Given this list of marker genes Lmf1, Cables1, Gimap9, Dcc, Esr1, H2-D1, C1qtnf3, Cxadr, Cyp2c55, Acot2, Wscd2 (NCBI Gene Id 320916), Cxcl15, Anks3, Nptxr, Zfp746, ENSMUSG00000133272, Ahrr, Krtap1-5, Slit3, Enpp2, Parm1, Itgb5, 4930453N24Rik, Lyz2, Fbxo2, Slc4a10, Klf2, Col2a1, Endod1, Nat3, Plekha7, Cdh17, Lcp1, Agmo, Loxl4, Lama5, Camk4, Scarb2, Cpeb2, Col19a1, Ppm1l, Sema3d, Sod3, Spef2, Lyz1, Slamf9, Eppk1, Iqcg, Racgap1, Lratd2, H2-DMa, Hira, Macc1, Pcolce2, Sdsl, Phlda2, Myo1d, Cd59a, Csdc2 (NCBI Gene Id 223704), Ly6f, Rex2, Cep72, Galnt13, Sema3c, Vav3, Wnt7b, Pycr1, Rasgrp3, Erlec1, Tacc1, Fkbp10, Pgbd5, Gvin1, Ddx18 (NCBI Gene Id 66942), Kcnmb1, Hoxd13, H2-K1, Pde4b, Ly6g2, Fam107a, Mlip, Mcpt8, B4galnt4, Tent5a, Tgfb2, AU021092, Aplp1, Asrgl1, Gtsf1, Tspan13, Ntn4, Sh3bgr, Efna5, Lrrn4cl, Atf3, Colec10, Aldh1a7, Upk3b (NCBI Gene Id 231783), Aars2, Slc2a3, Slc22a18, Itih5, here is a description of the gene set: from publication Gaussmann A, Wenger T, Eberle I, Bursen A, Bracharz S, Herr I, Dingermann T, Marschalek R (PMID 17130830) Down-regulated genes from the set A (Fig. 5a): specific to cells expressing MLL-AF4 fusion protein alone. The reciprocal chromosomal translocation t(4;11) is correlated with infant, childhood, adult and therapy-related high-risk acute leukemia. Here, we investigated the biological effects of MLL.AF4, AF4.MLL or the combination of both reciprocal fusion proteins in a conditional in vitro cell culture model system. Several parameters like cell growth, cell cycling capacity, apoptotic behavior and growth transformation were investigated under physiological and stress conditions. Co-transfected cells displayed the highest resistance against apoptotic triggers, cell cycling capacity and loss-of-contact inhibition. These analyses were complemented by gene expression profiling experiments and specific gene signatures were established for each of the three cell lines. Interestingly, co-transfected cells strongly upregulate the homeobox gene Nanog. In combination with Oct4, the Nanog homeoprotein is steering maintenance of pluripotency and self-renewal in embryonic stem cells. Transcription of Nanog and other stem cell factors, like Oct4 and Bmi1, was verified in biopsy material of t(4;11) patient cells which express both reciprocal t(4;11) fusion genes. In conclusion, the presence of both reciprocal MLL fusion proteins confers biological properties known from t(4;11) leukemia, suggesting that each of the two fusion proteins contribute specific properties and, in combination, also synergistic effects to the leukemic phenotype. species: Mus musculus Mouse Gene Set: GAUSSMANN_MLL_AF4_FUSION_TARGETS_A_DN